The following is a description of a gene set: Human Gene Set: HP_ELEVATED_SYSTOLIC_BLOOD_PRESSURE Elevated systolic blood pressure studied in species Homo sapiens Abnormal increase in systolic blood pressure., and this is the list of marker genes: ATP1B1, PTGIS, CYP3A5, STOX1, AVPR2, CORIN (NCBI Gene Id 10699), AGTR1, GNB3, ECE1, RGS5, FLT1, NOS3, ADD1